The following is a description of a gene set: Human Gene Set: FUNG_IL2_TARGETS_WITH_STAT5_BINDING_SITES Interleukin-2 (IL-2) mediates cell cycle progression and antiapoptosis in human T cells via several signal transduction pathways. The Tax protein of the human T-cell leukemia virus type I (HTLV-1) deregulates cell growth and alters the role of IL-2 in infected cells. However, Tax-immortalized cells stay dependent on IL-2, suggesting that events besides HTLV-1 gene expression are required for leukemia to develop. Here, IL-2-dependent and -independent events were analysed in a human T cell line immortalized by Tax. These studies show that, of the signaling pathways evaluated, only STAT5 remains dependent. Microarray analyses revealed several genes, including il-5, il-9 and il-13, are uniquely upregulated by IL-2 in the presence of Tax. Bioinformatics and supporting molecular biology show that some of these genes are STAT5 targets, explaining their IL-2 upregulation. These results suggest that IL-2 and viral proteins work together to induce gene expression, promoting the hypothesis that deregulation via the constitutive activation of STAT5 may lead to the IL-2-independent phenotype of HTLV-1-transformed cells. Genes with putative STAT5 binding sites; up-regulated by IL2 in both primary thymocytes and T1 cells (primary thymocytes immortalized by Tax, an HTLV-1 encoded gene). from publication Fung MM, Chu YL, Fink JL, Wallace A, McGuire KL (PMID 15735688) species: Homo sapiens, and this is the list of marker genes: NOP16, SOCS2 (NCBI Gene Id 8835), CCND2, DKC1, IL2RA, LIF, LTA